The following is a description of a gene set: Mouse Gene Set: GOBP_INTRINSIC_APOPTOTIC_SIGNALING_PATHWAY_IN_RESPONSE_TO_DNA_DAMAGE_BY_P53_CLASS_MEDIATOR The series of molecular signals in which an intracellular signal is conveyed to trigger the apoptotic death of a cell. The pathway is induced by the cell cycle regulator phosphoprotein p53, or an equivalent protein, in response to the detection of DNA damage, and ends when the execution phase of apoptosis is triggered. species: Mus musculus, and this is the list of marker genes: Ep300, Aen, Trp63, Usp28, Dyrk2, Topors, Chek2 (checkpoint kinase 2), Brca2, Knl1, Marchf7, Cd44 (CD44 antigen), Muc1, Bbc3, Bcl2l12, Phlda3, Ifi204, Cdkn1a, Pmaip1, Hipk2, Triap1, Mif, Snw1, Msh2, Pycard, Trp73, Hipk1, Hnrnpk, Bag6, Kdm1a, Atad5, Nupr1, Tmem109, Cd74, Rpl26, Steap3, Trp53, Sirt1 (sirtuin 1), Ppp2r5c, Shisa5, Ddit4, Pml, Bcl3, Cdip1, Rps27l, Ell3, Uri1, Zfp385a